The following is a description of a gene set: Human Gene Set: HP_URETERAL_STENOSIS Ureteral stenosis The presence of a stenotic, i.e., constricted ureter. species: Homo sapiens, and this is the list of marker genes: DSTYK, PRTN3, SIX1, PIGL, HNF1B, APC2, HOXA13, EHMT1, GNB1, NSD1, CTLA4, BRF1, SOX17, DHCR7, ZMYM2, FLNA, EYA1, PIGT, SLC26A1, SETBP1, HLA-DPB1, SLC35A2, SIX5, MYOD1, TBX18, YY1, PTPN22, KDM6A, SF3B2 (NCBI Gene Id 170474), KMT2D, NODAL, HLA-DPA1, CDH11